Given this list of marker genes MSTN, MIR204, MYOD1, MIR1-1, MIR133B (NCBI Gene Id 442890), MIR134, MIR133A1, MIR10A, MIR499A, here is a description of the gene set: Human Gene Set: GOBP_NEGATIVE_REGULATION_OF_MYOBLAST_PROLIFERATION Any process that stops, prevents or reduces the frequency, rate or extent of myoblast proliferation. species: Homo sapiens